The following is a description of a gene set: from publication Hervas-Stubbs S, Riezu-Boj JI, Gonzalez I, Mancheño U, Dubrot J, Azpilicueta A, Gabari I, Palazon A, Aranguren A, Ruiz J, Prieto J, Larrea E, Melero I (PMID 21108462) Genes up-regulated in CD8 T cells stimulated by IFNA2 versus those activated by anti-CD3 and anti-CD28. studied in species Homo sapiens Human Gene Set: GSE17301_IFNA2_VS_IFNA2_AND_ACD3_ACD28_STIM_CD8_TCELL_UP IFN alpha mediated gene expression pattern. The effect of IFN alpha on human CD8 T cells responding to antigen (signal 1) and costimulatory signals (signal 2) provided by beads coated with anti-CD3 and anti-CD28 mAbs. This analysis examined the effects of IFN alpha on human CD8 T cells responding to antigen (signal 1) and costimulatory signals (signal 2) provided by beads coated with anti-CD3 and anti-CD28 mAbs. Magnetically sorted untouched CD8+CD45R0- T cells from three different donors were unstimulated or stimulated with IFNa2b or with anti-CD3/CD28 Beads alone or along with IFNa2b or IFNa5 for 48 hours. Individual mRNA samples were analyzed using HG-U133A 2.0 array gene chips., and this is the list of marker genes: HGSNAT, BTN3A1, LPIN1, FYCO1, KDM7A, SEPTIN11, TBC1D2B (NCBI Gene Id 91449), ETHE1 (ETHE1 persulfide dioxygenase), RIOX2, TTN, KIF21B, PRCP, AVL9, GTDC1, PCYOX1L, BNIP3, LIPT1, DIAPH1, POLG2, INTS6, GAPVD1, MSANTD2, BAG4, ARHGAP17, ZNF189, FBXL5, KLHDC4, S1PR1, FHIP2B, DOP1A, VAMP4, ZCCHC2, PUS3, PITPNC1, ROBO1, TTC17, RAB22A (RAB22A, member RAS oncogene family), PCCA, TCF20, RAB5B, DDX60, SOAT1, DIPK1A, NAA60, VAMP5, RAB3GAP1, CFP, HOXB2, ARL2BP, SERPINI1, KLHL21, ZNF354A (zinc finger protein 354A), GIMAP4, KLHL2, WIPF1, NCF1C, HMOX2, NPAT, FUT8, ZFYVE16, XPC, ZC3HAV1, PAPOLG, CREBBP, RUBCN, CDH1, CCDC88C, ATXN1, OTUD4, QTRT2, SYNJ2BP, HIVEP1, CCL5, SLC25A15, IFIT1, ST3GAL5, SMAD7, QRSL1, RSU1, TAOK3, RIPOR2, XYLT2, SLC18A2, HEATR3, ACAA1, CD55, ZNF217, SERINC5, FBXL4, CLIP1, PLXDC1, TRIM32, C10orf88 (NCBI Gene Id 80007), PDIA5, OSBP, P4HTM, SGMS1, APPBP2, TMEM183A, GIN1, ARMCX2 (NCBI Gene Id 9823), ARAP1, TES, LRBA, CCDC25, ZNF304, ZNF200, MLX, TRAK2, ABCC4, KLRC3, OPTN, URGCP, C1orf56, CCPG1, GOLGA4, USP18, CTBS, NELL2, BTN3A3, PCTP, GPRASP1, KLHL36, FBLN2, SIPA1, RNF44, GZMK, RNF144A, C21orf91, BAK1, OGG1, SLC7A6 (NCBI Gene Id 9057), DACT1, C1orf50, CYTH1, MTERF4, ZFAND3, DENND4A, GNPDA1, MKRN2, CASP4, CLIC3, RPS6KA1, MAGT1, LITAF, PASK, SLFN12, RIGI, PDE3B, UBL3, TXK, PTPN4, ENTR1, SOX12, MTUS1, ATF7IP2, SPINK2, EXT2, ZNF493, ACVR1, IPCEF1, SEC31B, ZNF623, MAST3, TRAM2, ZNF329, PCK2, SMARCD3, PIK3C2A, SLC30A1, NT5E, ARHGAP12, RALGAPA1, CUL2, RAB33A, PLAG1, MGAT4A, SUN2, GNS, TPST2, PLCL2, SYNJ1, AP1AR, TMEM268, KDSR, COQ10B, MLYCD, EMP3, ZSCAN16, MT2A, ZNF274, STAT4, CPD, TMPRSS3, SRF, FKTN, S100A10, ENPP2, VWA8, EDEM2